Given this list of marker genes Map3k7, Map4k4, Map4k3, Map4k2, Map4k1, Map4k5, here is a description of the gene set: Mouse Gene Set: GOMF_MAP_KINASE_KINASE_KINASE_KINASE_ACTIVITY species: Mus musculus Catalysis of the phosphorylation of serine and threonine residues in a mitogen-activated protein kinase kinase kinase (MAPKKK), resulting in activation of MAPKKK. MAPKKK signaling pathways relay, amplify and integrate signals from the plasma membrane to the nucleus in response to a diverse range of extracellular stimuli.